The following is a description of a gene set: species: Homo sapiens Human Gene Set: WP_INFLAMMATORY_RESPONSE_PATHWAY Inflammatory response pathway, and this is the list of marker genes: FN1, IFNG, VTN, LAMB2, TNFRSF1A, LAMC2, CD86, IL5RA, CD28, IL2RG, THBS3, THBS1, ZAP70, COL3A1, IL2, LAMC1, IL5, COL1A1, IL2RA, IL2RB, COL1A2, IL4, TNFRSF1B, LCK, CD80, CD40LG, IL4R, CD40, LAMA5, LAMB1